Given this list of marker genes NT5E (5'-nucleotidase ecto), AMPD3, NT5C1A, ADA, XDH, here is a description of the gene set: The chemical reactions and pathways resulting in the breakdown of AMP, adenosine monophosphate. Human Gene Set: GOBP_AMP_CATABOLIC_PROCESS studied in species Homo sapiens